The following is a description of a gene set: Uncontrolled eye movements Human Gene Set: HP_UNCONTROLLED_EYE_MOVEMENTS studied in species Homo sapiens, and this is the list of marker genes: GABRB3, POMGNT1, CACNA1H, GABRG2, ADORA2A, GABRA1, SLC2A1, JRK